The following is a description of a gene set: Genes up-regulated in T reg cells from aged PPARG knockout mice: visceral adipose tissue versus lymph node. species: Homo sapiens We identified Pparg as a major orchestrator of the phenotype of adipose-tissue resident regulatory T cells (VAT Tregs). To establish the role of Pparg in shaping the VAT Tregs gene profile and cell dynamics, Tregs from lymph nodes and visceral adipose tissue of mice sufficient and deficient of Pparg expression in Tregs were double sorted for microarray analysis. Human Gene Set: GSE37532_VISCERAL_ADIPOSE_TISSUE_VS_LN_DERIVED_PPARG_KO_TREG_CD4_TCELL_UP from publication Cipolletta D, Feuerer M, Li A, Kamei N, Lee J, Shoelson SE, Benoist C, Mathis D (PMID 22722857), and this is the list of marker genes: NT5E (5'-nucleotidase ecto), MTA2, IGBP1, MCM3, PBK, HCLS1, MAPKAPK5, PRDX4, NUDCD3, SLC15A2, BLOC1S6, CALR, METAP1, SLC2A3, GABARAPL1, CD2, GNAQ, TSHZ1, RFC3, FEZ2, PDP1, WDR76, ZMAT3, RNPEP, GOPC, PPP1R15A, MIR361, MANBA (mannosidase beta), FOXO4, COMMD3, AMFR, MPI, CYRIB, EIF2AK3, SMARCD1, CD53, SELENOF, CUL2, ODC1, ANKRD50, TRIT1, SLC35D1, DIS3L, LAPTM5, NIT2 (nitrilase family member 2), GYG1, PA2G4, SRI (sorcin, NCBI Gene Id 6717), CDKN3, ERLIN2, SLC25A51, CD4, CHST10, KLF6, TTLL1, NEK3, PLEKHO2, CAMK4, GRIA3, TMEM14A, ZDHHC23, UFD1, MTX2, ZXDC, RRM1, PLK2 (NCBI Gene Id 10769), CHEK1, CPPED1, KIF1B, BBS10, MYH9, CDK5RAP1, HDDC2, USP3, ASB8, SQOR, HADHA, SLC25A20, SFT2D2, NAA20, PSMD7, NMRK1, BTBD1, ELF2, SMAP2, DENND4A, TMPRSS5, FBXO47, BCL2L13, TTC19, NAAA, TSG101, SNORD73A, PSMD5, N4BP1, VDAC3, ACADSB, SNX1, MLX, GZF1, MTMR9, LRRC61, TTC32, TUBGCP2, TAF12, ZC3HAV1, APOB, TGDS, NF2, EPSTI1, METTL15, ZEB1 (NCBI Gene Id 6935), OXSM, BPNT2, ASNS, HPGDS, RBM34, TAX1BP3, ANKRD10, SLC4A7, MFSD11, CD99L2, TEX2, PIP4K2C, CAMK2D, C9orf78, LCA5 (lebercilin LCA5), EDEM1, SEPTIN6, GGTA1, DYNC1I2, TEX15, PTPRJ, VDAC1, EI24, RAB27A, PVR, PLEKHB2, MXD1, TPRKB, PHLPP1, OMA1, DNAJC15, ENTPD1, STAU1, DARS2, CFDP1, DHX58, AGA, CBX5, SARS1, CTNS, STAMBP, RDH12, SLC30A6, ANGPTL1, KLHDC10, ARL6IP1, RCN2, STIL, THOC7, C1GALT1C1, CDC42SE2, PHLDA1, SLC25A24, LRIG2, IRGM, CCDC117, USP10, SCRN3 (secernin 3), NAA38, TSPYL4, ANLN, LPIN1 (NCBI Gene Id 23175)